Given this list of marker genes FGFR4 (fibroblast growth factor receptor 4), GLMN, DEGS1, FIRRE, PCGF3-AS1, KLHL42, GAS6, PAN3, BDP1, CERS2, OGDH, MTCH2, PAF1, UQCRFS1, ZNF449, GIT1, INPP5D, RBAK, TRIM47, ENSG00000248161, GABPA, OTUD4, USF2, MET, ZFX, KANK1, RNF138, GTF2IRD1, PAIP2B, IGF2BP1, MPDU1, ST3GAL4, TSEN2, MTR, FAM193A, TCF3, NRAP, INO80D, COL4A2, LUC7L2, SCCPDH, DCT, here is a description of the gene set: Human Gene Set: MARIADASON_REGULATED_BY_HISTONE_ACETYLATION_DN from publication Mariadason JM, Corner GA, Augenlicht LH (PMID 10969808) Cluster 10: genes down-regulated in SW260 cells (colon cancer) by sodium butyrate and TSA with the same kinetics with which each alters the level of histone H4 acetylation. The short-chain fatty acid butyrate, produced by microbial fermentation of dietary fiber in the large intestine, is a physiological regulator of major pathways of colonic epithelial cell maturation: cell cycle arrest, lineage-specific differentiation, and apoptosis. Microarray analysis of 8,063 sequences demonstrated a complex cascade of reprogramming of SW620 colonic epithelial cells upon treatment with butyrate characterized by the progressive recruitment of gene sets as a function of time. Comparison with the effects of trichostatin A, in conjunction with differences in the kinetics of alteration of histone acetylation induced by butyrate and trichostatin A, identified subsets of induced and repressed genes likely coordinately regulated by altered histone acetylation. The butyrate response was also compared in detail with that of sulindac, a nonsteroidal anti-inflammatory drug with significant chemopreventive activity for colon cancer, and curcumin, a component of mustard and curry structurally and functionally related to sulindac that also has chemopreventive activity. Although gene clusters were identified that showed similar responses to butyrate and sulindac, the data were characterized by the extensive differences in the effects of the two agents. This was striking for functional classes of genes involved in signaling pathways and in cell cycle progression, although butyrate and sulindac induce a similar G0-G1 arrest, elevation of beta-catenin-Tcf signaling, and apoptotic cascade. As regards cell cycle arrest, the underlying mechanism in response to butyrate was most similar to that of the Caco-2 cell line that had spontaneously undergone a G0-G1 arrest and least similar to the G2-M arrest stimulated by curcumin. Thus, high-throughput microarray analysis of gene expression profiles can be used to characterize and distinguish the mechanisms of response of colonic epithelial cells to physiological and pharmacological inducers of cell maturation. This has important implications for characterization of chemopreventive agents and recognition of potential toxicity and synergies. The data bases, gene clusters, and analyses are available at http:// sequence.aecom.yu.edu/genome/. species: Homo sapiens